Given this list of marker genes USP45, RXRA (retinoid X receptor alpha), ADAM28, TMPRSS11D, CCDC39, here is a description of the gene set: Genes predicted to be targets of miRBase v22 microRNA hsa-miR-574-3p in miRDB v6.0 with MirTarget v4 prediction scores > 80 (high confidence targets). Human Gene Set: MIR574_3P species: Homo sapiens from publication Chen Y, Wang X (PMID 31504780)